Given this list of marker genes AXIN1, PPP2R5E, PPP2R5D, GSK3B, PPP2R5A, AMER1, PPP2CA, CSNK1A1, PPP2R1B, PPP2R5B, PPP2CB, PPP2R1A, APC, PPP2R5C (protein phosphatase 2 regulatory subunit B'gamma), here is a description of the gene set: Reactome Pathway: Signaling by AXIN mutants part of: Signaling by WNT in cancer species: Homo sapiens AXIN1 and AXIN2 are critical scaffolding proteins of the beta-catenin destruction complex and make protein-protein interactions with several of the other complex components including APC, GSK3, CK1 and beta-catenin itself through specific domains. Because of its role in promoting the degradation of beta-catenin and thereby restricting WNT signaling, AXIN1 is regarded as a tumor suppressor; consistent with this, biallelic mutations in AXIN1 that abrogate its expression or result in the production of truncated proteins have been identified in some human cancers, notably in hepatocellular and colorectal carcinomas and medullobalstoma.